The following is a description of a gene set: Any process involved in the maintenance of an internal steady state at the level of the multicellular organism. species: Homo sapiens Human Gene Set: GOBP_MULTICELLULAR_ORGANISMAL_LEVEL_HOMEOSTASIS, and this is the list of marker genes: PRMT1 (NCBI Gene Id 3276), B2M, TFRC, HADH, MKKS, TRPM2, OXT, EDN2, CSK, PIK3CD, ETV2, SLC25A44, GDF15, LACRT, CYP4F2, AQP4, NCSTN, PRKAA1, CNGB1, TLR4, CDK6, ADAM8, APOE, SMO, EPB42, CRTC3, TUB, ITGB3, MAFB (NCBI Gene Id 9935), MIR17HG, ASXL1, ABCA12, TF, TWIST1, UBB, MUC4, TMOD3, LDB2, GCNT4, IL4, TSPO2, CTSH, FOXC1, IL17A, PRKCA, NOX3 (NADPH oxidase 3), NF1, ABCC6, KIT, ADRB1, MAP2K6, WHRN, TNF, BCL10, AVP, PRKDC, ELOVL6, AQP3, PRDX2, TRPV1, ZFPM1, CCR7, RP1, ANXA1, CRACD, EIF2AK1, PERP, PMAIP1, IL1A, LTBP3, ZNHIT1, CDH5 (NCBI Gene Id 1003), CDIN1, CCDC198, ACTN3, KSR2, CTNNB1, MIF, GIGYF2, HIPK2, G6PD, ADIPOR2, LIPA, TGFB2, HSPA1A, GATA2, COL6A1, RMI1, SLC40A1, TNFRSF13B, AP3B1, WNT10B, ARMCX1, BRD1, METRNL, ABCA3, LCN2, SLC39A3, SLN, ZNF830, ELOVL3, RPS14, SLC25A38, PPRC1 (PPARG related coactivator 1), IL10RA (NCBI Gene Id 3587), CLN8, IL20RA (interleukin 20 receptor subunit alpha), PRKACG, PLCL2, KDR, ZFY, APLN, CNTN2, SLC28A2, CIDEA, MERTK, IL18R1, NMU, TMEM64, NFKBIZ, ABCA4, SCD, NCAPG2, CSF1, ACHE, TNS2, BCL6, IL7, AMPD2, NCDN, GHRL, CDHR1, MPL, STAT3, EBF2, PRLH (NCBI Gene Id 51052), ALK, KDM3A, RHEX, ABHD6, LGALS2, SENP1, INHA, ACSL1, NPR3, CITED2, TJP1, MINAR2, VPS54, IL4R, MLLT6, ZNF251, PKP3, TNFRSF11A, NDN, ACVR2A, ARSG, ADAMTS5, FOXO3, DNAJA3, CAV1, ITGB6, SLC25A25, NOX4, SLC39A8, USH1C, CUBN, KCNQ1, NKIRAS2, CCN3, APBB2, TGFBR3, RB1, CALCA, KAT7, AHSP, CNOT3, PECAM1, UFL1, MFAP2, MFHAS1, CIB2, TMEM63B, LPCAT1, PHOX2B, PTGES, SERPINA3, HYAL2, ID2 (NCBI Gene Id 3398), RUFY4, PRDX1, TSHR, IQCB1, AIPL1, PTK2B (NCBI Gene Id 5748), SIT1, BBLN, BBS4, HEATR3, HBZ, CROCC, TRPV4 (transient receptor potential cation channel subfamily V member 4), CARD11, USH1G, LMO1, MAEA, TFE3, STK39, ANKH, ZNF16, SPATA7, KMT2A, PKN1, ZNF516, CRTC1, GFRAL, APPL2, OGT, S1PR1, ADGRV1, MC3R, BBS12, PTGER3, VSIG1, C1QTNF4, TRPM8, NLRP6, ILDR1 (immunoglobulin like domain containing receptor 1), PTH2R, CCN2, AKAP11, HCAR2, MYO5B, SH3GL2, DMD, ACACA, HDAC6, MKS1, SRC (NCBI Gene Id 6714), NAPSA, SLC48A1, QKI, MIR222, NAGLU, ASCL3, POC1B, SUCNR1, BAX, ARMS2, NOS3, STAT1 (signal transducer and activator of transcription 1), ZC3H8, PRKAB1, AKR1B1, NLE1, FOXP3, EDNRB, CYP11B2, SMAD5, MAK, TGFB1, EPG5, LNPEP, ARNT, ACADL, CYBRD1, PPP1R13L (NCBI Gene Id 23453), PRKACB, F11R, ANKRD54, TFR2, SYK, DDIT3, GLIS2, LRRK1, PLA2G2A, SCNN1A, SMARCA4, CCNB2, ACTG1, GPX1, SLC35D3, OCIAD1, MED1, SPI1, NR1D2 (NCBI Gene Id 9975), DCSTAMP, ZNF423, SLC25A40, CRB1, PASK, NKX2-3, BMP8A, STAT5B, ABCB10, GLUL, RPS19, BCL2, FTO, YAP1, GPR137, ACIN1, DOCK10, STK11, CSF1R, NMUR2, MBP, SLC11A1 (solute carrier family 11 member 1), HOXA13, CYP4F12, CEBPG (NCBI Gene Id 1054), HAS2, ALMS1, CHMP4B, DOCK7, KLF13, KCNJ1, BAP1, SELENOW, CADPS2, RAC2, KLF2 (KLF transcription factor 2), TSC22D3, RPA1, NKIRAS1, CEBPA, DEF8, HJV, CD36, FOXN1, TNFSF14, NFIB, USP45, AFP, HMGB1, THRA, BPGM, PIWIL4, MAPK11, CASP3, COL3A1, MPIG6B, CD2AP, INAVA, FLT3, CTSK, RAG1, HOXB6, FSTL1, PROM1, TMEM14C, ADCY6, WDR48, ODAD3, ETS1, NCKAP1L, FSHB, TRIM58, RAC1, TUBA1A, IL2, SOS1, IREB2, PDGFC, TMEM18, SLC12A2, FOXO1, L3MBTL3, SLC1A1, NDP, CRISPLD1, RHO, BTBD9, KDM6B, SASH3, ABCC8, ELP6, SOX4 (SRY-box transcription factor 4), ZFP36, ILDR2, CD38, SCT, RBPJ, GRB10, GPI, YPEL4, AQP2, LCA5, RCN3, SGIP1, PTH, FMO4, UCP1, TCIRG1, DLL1, TLE3, PCTP, SOS2, BTK, CYTL1, RC3H1, HSF1 (NCBI Gene Id 642255), SMAP1, SRF, TLR9, COL2A1, JMJD6, KDM1A, NTSR1, PRDX5, NEO1, CPT2, ANGPT1, CARTPT, DBH, PRCP, ALPL, TMEM119, GPR82, VSTM4, ZBTB7B, FH, EMCN, ALAS1, PTGS2, NR1D1, SLC22A5, CCDC66, SH2B2, RACGAP1, FABP4, TRIM32, PRLR, JAK3, KLF1, ACTB, SCNN1G, MBL2, FABP5, BPIFA1, MFN2, P4HTM, DIAPH3, TJP2, YBX2, FAS (Fas cell surface death receptor), BOLA3, SLC46A2, ERRFI1, CYLD, RP1L1, CDH2, JAK2, FANCE, LAT, ERCC6, TJP3, PPARGC1A, AXL, APC, NEUROD1, ADORA1 (NCBI Gene Id 134), RAB3D, NEMP1, ACOT13, SART3, FBXO21, EGR1, NRDC, CMKLR1, RDH12, PTH1R (parathyroid hormone 1 receptor), ADIPOQ, EXT1 (exostosin glycosyltransferase 1), GJB6, MTF1, GATA1, PCDH15, LAMC1, ARHGEF5, RAC3, LPCAT3, MLXIPL, VPS13B, ZNF675, MTHFD1, FMO2, PIANP, SP3, ADRB3, SLC2A1, WFS1, DIO2, AKT3, CAMLG, CD34, AQP6, ARAP1, BGLAP, EHMT1, OCLN, BMP4, FCER1G, GNAT2, PWWP2B (NCBI Gene Id 170394), DYNC1H1, MAPK14, HOXC10, COMP, DMTN, LYAR, INPP5D, SCRIB, GPR137B, ARID4A, CHST3, NANOS1, TFF2, MUC2, NT5E, BBS2, SIGLEC15, ABL1, PCSK1N, TMPRSS6, SPNS2, GDF3, MB, ADGRF5, LYN, CEBPB, PRDM16, TAL1, ALAS2, IL20RB, TFF3, LGR4, DRD2, PPARGC1B, CYP4A11, PACS1, XKR8, CRB2, TNFRSF17, CHMP5, RPS17, ADGRG1, UBA5, GPRASP2 (NCBI Gene Id 114928), TRIM10, SOD2, PDE4B, F2R, ADIPOR1, CD74, TCEA1, TPP1, ACVR1C, INHBA, SLC4A1, BCR, RCOR1, MFSD2A, ATF4, CX3CR1, OAS1, MEF2C, IFT80, UCP2, IGF1R, HAMP, DNASE2, ADA, NXNL2, SLC7A11 (solute carrier family 7 member 11), GNAS, MUC6, NOVA2, MIR221, PIK3CA, BARD1, P2RX7, IL2RA, MUC13 (NCBI Gene Id 65118), UMOD, TSPAN12 (NCBI Gene Id 23554), MYB, SNX10, GPR15LG, BCL2L11, GPR55, FOXC2, P2RX4, GJA1, RRN3, NPHP3, GADD45G, EXT2, EPAS1, PLEKHM1, SQSTM1, SKIL, ACADVL, TBL1XR1, ACACB, DOCK11, IRF4, NOTCH1, OCIAD2, BBIP1, WDR37, CCR4, LEP, HTR4, ACOT11, IAPP, USH2A, ST6GALNAC1, GPR3, RASAL2, RIPK3 (NCBI Gene Id 11035), ACVR2B, G0S2, FOSL2, HOXA5, WNK3, SCX, BSCL2, ARMCX5-GPRASP2, NOD2, HSCB, SEPTIN4, HTR2A, ITPKB, CXADR, NR1H2, FLVCR1, DRD1, NOVA1, TNFAIP3, GATM, PPP2CA, BMP6, ISG15, FAM3D, MIR486-1, BBS10, MIR204, ADAR, SOD1, ADAM17, KMT2E, RHAG, HNRNPU, NAPEPLD, SLC4A2, AQP1, PRKAB2, PTPN2, IL7R, PTBP3, SIVA1, ALDH1A1, BLOC1S6, VEGFA, NR4A3, PPP2R3C, ATP6V1B1, LETMD1, TSKU, TRPV2, LPIN1, CLDN3, WNK4, CXCR4, IL1B, PGAM5, RPE65, NFE2L1, JAM2, AKT1, ZFP36L1, HSPA1B, PPP2R1A, PER2, ACP5, RHEB (Ras homolog, mTORC1 binding), PICALM (NCBI Gene Id 8301), PLAC8, HIF1A, ID1, BBS1, MTCH2, EIF4G1, ZEB2, ABAT, ATP1B2, HMOX1, MYCT1, FADD (NCBI Gene Id 8772), RAB7A, PBLD, HFE, ARRDC3, TULP1, CDH3, COL14A1, TRAF6, ESRRG, STAT5A, RBP4, AIM2, PRRC1, LAMA4, ESAM, IKZF1, TP53INP2, UBAP2L, PLCL1, SPP1, CLDN12, PLA2G10, EPO, CXCL6, FCAR, SIRT1, LAMA2, CORO1A, MAPK8, IL13, KITLG, RRP8, IL6, EZH2, WWTR1, SFXN5, IL15, HMGB2, FECH, UBASH3B, TRAF3IP2, SLC25A5, INPP5K, DECR1, VCL, PPARD, FOXA3, FMO1, FBXL5, BAK1, BSG, FFAR4, HEPH, SCTR, NXNL1, ITGB1, STAT6, PM20D1, LSR, TSPAN9, ADCYAP1, OMA1, GPR174, SCNN1B (sodium channel epithelial 1 subunit beta), LGALS9, MC4R, CDH23, FSHR, NR1H3, CDK5RAP3, FGF21, ABCB1, OXTR, BMAL1, MRAP2, SUV39H1, CLSTN3, FAM210B, HCLS1, TNFSF11, BRINP1, HCRT, ZBTB7A, MEX3C, TNFSF13B, GPR183, CARD9, TMEM63A, LRRC19, PRDM14, GATA3, VGF, IRX3, GUCA2B, DRAM2, SORL1, MIP, PTPN11, SOX9, CLDN18, HSPA9, VPS13A, ATP5IF1, ADRB2, RASSF2, IGF2BP2, KRAS, CLDN1, IL18 (NCBI Gene Id 3606), SLC11A2, PRKACA, P2RY14, SLC27A1, RC3H2, IKBKG, XIAP, ERCC2, STRAP, SIRT6, SPRR2A, PDK4, JAM3 (NCBI Gene Id 84887), PRKAA2, PPP3CB, IP6K1, SLC15A4, LDB1, CLCN3, CFTR, ESRRB, SLC1A5, PEMT, GCNT2, SH2B3, IHH, GAPT, EMX1 (empty spiracles homeobox 1), GBA1, PIK3CB, SFTPD, FLCN, NR1I2, GPAM, CCR2, SFXN1, DYRK3, ACVR1B, PRICKLE1, POLB, HDAC3 (histone deacetylase 3), TFF1, PKNOX1, CLDN5, SPTA1, KLHL10, RPS24, CLRN1, LEPR, NPHP4